Given this list of marker genes Bmp2, Twist1, Smad4, Dchs1, Isl1, Acvrl1, Tbx5, Tbx20, Tgfb3, Acvr1, Rbm24, Tgfb1, Jag1, Gata5, Thbs1, Tbx3, Bmp4, Tgfb2, Msx2, Mdm2, Tgfbr1, Fgf8, Snai2, Tbx2, Heyl, Erbb3, Cplane2, Sox9, Eng, Nos3 (nitric oxide synthase 3, endothelial cell), Adamts5, Tgfbr2, Bmpr2, Snai1, Gata4, Foxf1, Nfatc1, Smad2, Bmp7 (NCBI Gene Id 12162), Nog, Robo2, Notch1, Mdm4, Robo1, Msx1, Hey1, Tmem100, Bmpr1a, Epha3, Aplnr, Cited2, Bmp5, Rbpj, Nedd4, here is a description of the gene set: The progression of a cardiac cushion over time, from its initial formation to the mature structure. The endocardial cushion is a specialized region of mesenchymal cells that will give rise to the heart septa and valves. species: Mus musculus Mouse Gene Set: GOBP_ENDOCARDIAL_CUSHION_DEVELOPMENT